The following is a description of a gene set: from publication Li P, Burke S, Wang J, Chen X, Ortiz M, Lee SC, Lu D, Campos L, Goulding D, Ng BL, Dougan G, Huntly B, Gottgens B, Jenkins NA, Copeland NG, Colucci F, Liu P (PMID 20538915) Genes up-regulated in ITNK cells (T-lymphocyte progenitors (DN3 cells) reprogrammed to natural killer (NK) cells by ablation of BCL11B gene), compared to the parental DN3 cells. studied in species Mus musculus T cells develop in the thymus and are critical for adaptive immunity. Natural killer (NK) lymphocytes constitute an essential component of the innate immune system in tumor surveillance, reproduction, and defense against microbes and viruses. Here, we show that the transcription factor Bcl11b was expressed in all T cell compartments and was indispensable for T lineage development. When Bcl11b was deleted, T cells from all developmental stages acquired NK cell properties and concomitantly lost or decreased T cell-associated gene expression. These induced T-to-natural killer (ITNK) cells, which were morphologically and genetically similar to conventional NK cells, killed tumor cells in vitro, and effectively prevented tumor metastasis in vivo. Therefore, ITNKs may represent a new cell source for cell-based therapies. Mouse Gene Set: LI_INDUCED_T_TO_NATURAL_KILLER_UP, and this is the list of marker genes: Tiam1, S100a13, Sema4a, Tspo, Neurl3, Med11, Vti1b, Pdlim7, Hgfac, Golm1, Cyb5r4, Osm, Adgrg5, Cxcr3, Lrrk1, Klre1, Niban2, Tmem120a (transmembrane protein 120A), Ehd4, Tnfrsf22, Hsd11b1, Tirap, Epop, B4galnt4, Vim, Egr1, Tnfsf10, Srgap2, Rbms1, Lasp1, Pea15a, Zcchc18, Iqgap2, Tnfrsf18, P2ry14, Gbp2, Nkg7, Gcnt2 (glucosaminyl (N-acetyl) transferase 2 (I blood group)), Gcnt1, Elovl1, Cxcl9, Osbpl3, Nt5e, Tubb6, Sgk1, Coro1c, Dhrs11, Sirt3, Cish, Nfkb1, Cdkn2a, Serpina3g, Napsa, Adgrg3, Ly6a, Kit, Itgad, Ifng, Sccpdh, Bscl2, Selenos, Ltb4r1, Batf3, Serp2, Mindy1, Ifi30, Fxyd5, Pkp3, Junb (NCBI Gene Id 16477), Gvin1, Prelid2, Slc24a3, Sh2d1b1, Sertad1, Plekho2, Fcer1g, S100a10, Stx11, Ccl5, 4930486L24Rik, Gpr18, Cyp51, S100a4, Ahnak, Cd69, Ly6g5b, Myo1f, Asb2, Nfil3, Prr7, Fnbp1, Lrp12, Ctsw, Tuba1c, Spp1, Myo1g, Vps29, Scin, Klk8, Serpine2, Ppib, Smagp, Slc19a2, Tnfrsf9, Bbln, Ppp3cc, Sh3bp2, Capzb, Tent5a (terminal nucleotidyltransferase 5A), Serpinb6a, Tmbim4, Ndfip1, Hvcn1 (hydrogen voltage-gated channel 1), Cxcr5, Itgb7, Arap3, Susd3, Ostf1, Gpc1, Gstp3, Sh3bgrl3, Egr3, S100a1, Jaml, Casp1, Hmgcs1, Itgae, Gm4777, Klhl30, Capn2, Prdx4, Gdpd5, Med10, Ccdc102a, Gm19590, Vps50, Tes, Pigz, Rab3d, Ccr5, H1f2, Gfod1, AA467197, Ctnna1, Mfsd10, Xcl1, Sdf2l1, Batf, Ifitm1, S100a11, Slamf7, Fes, St3gal6, Dusp5, Cd7, Pdzk1, Emp1, Arfgef3, Arl6ip5, Haao, 2900026A02Rik, Ptms, Tyrobp, Tnfrsf11b, Tmem154, Lrrc8c, Myl6, Havcr2, Kctd10, Chsy1, Anxa2, Cdkn1a, Arsb, H2-Q6, Furin (furin, paired basic amino acid cleaving enzyme), Plcg2, Upp1, Fam20a, Klrd1, Ifitm3, Gng2, Eci1, Tpst2, Tmem141, Dennd3, Ccl3, Msmo1, Vash1 (NCBI Gene Id 263410), Fosl2, Trf, Ccng1, Bhlhe40, Fam185a, Cd9, Dyrk3, Capg, Castor1, Pilrb1, Slc39a4, Sec61b, Tmem158, Tmem238, Zfp608, Riox2, Zbtb32, Crybg2, Ifitm2, Cldnd1, Sypl1, Dennd4a, Aqp9, Dok2, Dusp6, Taf9b, Xbp1, Traf1, Nrgn, Irak2, Mvp, Endod1, Ccl4, Crybg1, Ank (NCBI Gene Id 52488), Cd52, Litaf, Apobr, Lat2, Trpm6, Pim3, Avil, Snx18, Ncf4, Prmt2, Glipr1, F2rl2, Fxyd4, F2r, Lag3, Zfp296, Cdkn2b, Id2, Myo1e, Glrx, Uap1l1, B4galnt2, Slc2a6, Lta, Lgals3bp, S100a6, Hba-a1, Comt, Fcgr3, Evi2a, Kir3dl2, Asah1, Calhm6, Rgs1, Rab19, H2-Q7, Clnk, Stx7, Smco4, Lgals3, Cd244a, Sytl2, Slc52a3, 1700025G04Rik, Reep5, Miat, Gadd45g, Capns1, Cd63, Scimp, Prrc1, Gpr34, Serpina3f, Aldoa, Glipr2, Sidt1, Pltp, Samd9l, Gpr68, Plscr1, Dapk2, Gramd1b, Cotl1, B3gnt8, Irgm2, Pglyrp1, Rnf19b, Tmem126a, Prr13, Mlkl, Mapkapk3, Lgals1 (NCBI Gene Id 16852), Il18r1, Cstb, Ccnd2, Mt1, Pdgfa, Plp2, Sult2b1, Emilin2, Bag3, Cd160, Plpp2, Cx3cr1, Tnf, Khnyn, Ccn2, Gpr15, Dcxr, Hhex, Ftl1, Gm16372, Hk2, Ier3, Rom1, Otulin, Rhof, Rab4a, Errfi1, Fhl2, Hopx, Arf6, Lmna